Given this list of marker genes NEDD4, PDIA4, RB1, DDX52, IGF2R, SF3A1, TNFAIP1, ZBTB14, GGPS1, BAZ2B, POLG2, IL6, IFNGR1, RASA1, CSRP3, ZNF143, RBBP8, TAF12, TGIF1, KPNA1, ZNF84, GPR65, ITM2A, RFPL3S (NCBI Gene Id 10737), BPY2, VPS13D, GEM, WASL, APOM, ASTN1, NDUFS4, PLSCR1, GPM6B, LONP2, PRDX3, CCDC28A, SERPINB8, HCP5, SPAG6, PSMA5, ZBTB1, PGAP2, UGT8, USP34, PRPS2, CCL20, PGAP1, CD226, SULT1C2, GTF2H5, TNFRSF10B, FANCI, PDS5B, ORC4, GK, SP100, GTF2H2, ATF3, LPIN2, DNMT1, COX7A1, ATM, CLEC2B, ARG2, VPS8, LPL, ANP32E, MBD1, EBAG9, ZNF195, AP1S2, APOBEC3B, SLC25A12, RPS27A, B4GALT4, CXCL2, UTP25, FAM216A, GCSH, SMAD3, NDUFB6 (NCBI Gene Id 4712), UBE2L6, CARD8, NCOA6, RPL37A, HNRNPM, CD27, DHX8 (NCBI Gene Id 1659), MMP8 (NCBI Gene Id 4317), ADGRE5 (NCBI Gene Id 976), RAB22A, MFAP3, CD6, PDE4DIP, CENPC, IL23A, BCL6, IARS2, MDFIC, GEMIN4, SPP1, LGI1, PLAG1, CD9, TRAF1, ZNF273, IFT27, ATG14, SNRPE, RHOH, PLS3, ID3, DHRS3, IGFBP4, CCNG1, EMC2, SAT1, PPP1CC, PRIM1, TLL2, JAK2, IGF2BP3, ZNF318, OSGEP, PPP3CB, HNRNPH1, MAP2K4 (NCBI Gene Id 6416), PGGT1B, HMGN3, PTTG1, PSME2, ISG15, PEX3, SIAH2, GDE1, IFI16, TRAF6, HLTF, RAB29 (NCBI Gene Id 8934), FRY, FBP2, ZNF211, NPM1, TOPBP1, IFI44, NR4A2, BRD8, ATP6V1B2, HACD2, TAF15, ZNF473, UBE2K, NUCB2, SLC25A17, CD48, CTBS, RPS28, PRR3, PIK3CG, SUMO3, GGA3, SLAMF1, NUMB, SDHD, RBM19, SLC25A14, GNG5, CLPX, PIK3R3, ZEB2, BTN2A1, PDE8A, MTR, VWA8, SERPINE2, LYST, POU2AF1, GBP2, FABP5, APOOL, F13A1, CREBBP, NFKBIE, IRF1, SYNGR3, FUT2, LECT2, PPFIA2, RCHY1, GRM1, PIM2, SRP9, SLC27A2, TAF1B (NCBI Gene Id 9014), REL, C7, RPS16, UNC50, GAPDH, BTF3P11, here is a description of the gene set: from publication Anandasabapathy N, Victora GD, Meredith M, Feder R, Dong B, Kluger C, Yao K, Dustin ML, Nussenzweig MC, Steinman RM, Liu K (PMID 21788405) species: Homo sapiens Genes down-regulated in brain microglia versus bone marrow monocytes. Human Gene Set: GSE29949_MICROGLIA_BRAIN_VS_MONOCYTE_BONE_MARROW_DN To understand the functional relationship between brain dendritic cells (brain DCs) and other myeloid cells, we compared the gene expression profile of m/chDCs to that of bone marrow monocytes, brain microglia and classical spleen CD8+ and CD8- DCs. In order to obtain enough brain DCs for mRNA extraction, we expanded brain DCs with in vivo Flt3L treatment before purification.